Given this list of marker genes CD2AP, NUP133, PI4KA, TP53, COQ8B, F10 (coagulation factor X), NUP107, CRB2, ARHGDIA, MYH11, INF2, PLCE1, ELANE, TTC7A, SERPINE1, MVK, GAPVD1, NUP37, ANKFY1, COL4A3, HLA-DRB1, F5, KRAS, NCF2, ELP1, WT1, PDCD1, PALLD, STAT6, EMP2, EWSR1, NUP85, NAB2, PTPRO, DAAM2, MYO1E, MEFV, BCL2, ARHGAP24, FOCAD, CDKN2A, PALB2, CDC45, ANLN, NUP205, RABL3, NPHS2, ACTN4, CALR, NUP160, SMAD4, BRCA1, TNFRSF1A (NCBI Gene Id 8077), BCL6, PAX2, MAGI2, BRCA2, TBC1D8B, NUP93, NPHS1, SLC29A3, JAK2, APOL1, CFB, TRPC6, here is a description of the gene set: Abnormal peritoneum morphology An abnormality of the peritoneum. species: Homo sapiens Human Gene Set: HP_ABNORMAL_PERITONEUM_MORPHOLOGY